The following is a description of a gene set: Reactome Pathway: Regulation of PD-L1(CD274) transcription part of: Regulation of PD-L1(CD274) expression This event has been computationally inferred from an event that has been demonstrated in another species.<p>The inference is based on the homology mapping from PANTHER. Briefly, reactions for which all involved PhysicalEntities (in input, output and catalyst) have a mapped orthologue/paralogue (for complexes at least 75% of components must have a mapping) are inferred to the other species. studied in species Mus musculus electronically inferred by orthology from the curated human pathway, and this is the list of marker genes: H2ac13, H2ac10, H3c13, H3c7, H2ac6, H2bc11, H2ax, H4c9, H2ac12, Rbbp7, H2ac8, H4c1, H4c11, H2az2, Rbbp4, H4c6, H2ac22, H2ac15, H3c8 (H3 clustered histone 8), H3c10, H2bc9, H4c8, H4c4, H2ac4, H2bc1, H2bc13, H4c3, H3c6, H2ac24, H3f3a, H3c11, H2bc15, H3c4, H2bc7, H2bc3, H2bc22, H2bc27, H3c2, H2ac1, Ezh2, H3c3, H4c14, H2ac23, H3c15, H2ac11, H2ac7, H3c1, H4c17, H2bc12, H4c12, H4c18, H2ac19, H2ac20, H2bc8, H4c2